Given this list of marker genes SLITRK6, SULF1, GABRB3, EDNRA, NPTX1 (NCBI Gene Id 4884), SULF2, ARK2C, LRIG2, NPR2, ECE1, SERPINE2, COL25A1, SEMA3A, POU4F1, GABRA5, ADARB1, PRKCG, NTRK1, GABRB2, VCAM1, LRIG1, FBXO45, NRP1 (NCBI Gene Id 8829, neuropilin 1), EPHA4, EDN1, NTF4, LRIT3, ISL1, ITGA4, CHD7, here is a description of the gene set: The process in which a nerve invades a tissue and makes functional synaptic connection within the tissue. Human Gene Set: GOBP_INNERVATION studied in species Homo sapiens